Given this list of marker genes ELOA2, EPOP, ELOB, ELOC, ELOA, here is a description of the gene set: Human Gene Set: GOCC_ELONGIN_COMPLEX studied in species Homo sapiens A transcription elongation factor complex that suppresses RNA polymerase II pausing, and may act by promoting proper alignment of the 3'-end of nascent transcripts with the polymerase catalytic site. Consists of a transcriptionally active Elongin A subunit (about 100 kDa) and two smaller Elongin B (about 18 kDa) and Elongin C (about 15 kDa) subunits.